Given this list of marker genes Xrn1, Lsp1, Creg1, Dhrs7, Zfp36, Ogt, Cxcr4 (C-X-C motif chemokine receptor 4), Stk17b, Rassf3, Apobr, Taldo1, Csf3r, Fau, Gm2a, Cd300a, Nr4a1, Zfp36l2, Cst3, Arrdc3 (NCBI Gene Id 105171), Rbm38, Tgfbi, Pglyrp1, Rgs2, Kctd12, Pmaip1, Celf2, Mmp9, Lst1, Fos, Ipcef1 (NCBI Gene Id 320495), Ier2, Msrb1, Junb, Cd52, Ptgs2, H4c9, Cotl1, Btg2, Mrpl33, Tyrobp, Pi16, Mtpn, Gsn, here is a description of the gene set: Genes negatively differentially expressed in cell type: Neutrophil upon treatment with cytokine: IL-1α in mouse lymph nodes in vivo. species: Mus musculus Mouse Gene Set: CUI_NEUTROPHIL_IL1A_RESPONSE_DN Cytokines mediate cell-cell communication in the immune system and represent important therapeutic targets. A myriad of studies have highlighted their central role in immune function, yet we lack a global view of the cellular responses of each immune cell type to each cytokine. To address this gap, the authors created the Immune Dictionary, a compendium of single-cell transcriptomic profiles of more than 17 immune cell types in response to each of 86 cytokines (>1,400 cytokine-cell type combinations) in mouse lymph nodes in vivo. A cytokine-centric view of the dictionary revealed that most cytokines induce highly cell-type-specific responses. For example, the inflammatory cytokine interleukin-1β induces distinct gene programmes in almost every cell type. A cell-type-centric view of the dictionary identified more than 66 cytokine-driven cellular polarization states across immune cell types, including previously uncharacterized states such as an interleukin-18-induced polyfunctional natural killer cell state. from publication Cui A, Huang T, Li S, Ma A, Pérez JL, Sander C, Keskin DB, Wu CJ, Fraenkel E, Hacohen N (PMID 38057668)